The following is a description of a gene set: To identify tumor markers and differentiation markers for lung adenocarcinoma (AdC), we analysed expression profiles of genes against three cases of type II alveolar epithelial cells, bronchiolar epithelial cells, and bronchial epithelial cells, respectively, and 10 cases of AdC cells isolated by laser capture microdissection. Hierarchical clustering analysis indicated that AdC cells and noncancerous lung epithelial cells are significantly different in their expression profiles, and that different sets of differentiation markers are expressed among alveolar, bronchiolar and bronchial epithelial cells. Nine genes were identified as being highly expressed in AdC cells, but not expressed in noncancerous lung epithelial cells. Sixteen genes were identified as differentiation markers for lung epithelial cells. Real-time RT-PCR analysis of 45 lung AdC cases further revealed that expression of four tumor markers in AdC cells was significantly higher than that in noncancerous lung cells and that expression of ten differentiation markers was retained in a considerable fraction of lung AdC cases. Five tumor markers and seven differentiation markers were not expressed in peripheral blood cells. Similarities and differences in expression profiles between normal epithelial cells from different lung respiratory compartments and AdC cells demonstrated in this study will be informative for the molecular diagnosis of lung AdC. Differentiation markers for normal alveolar epithelium cells. Human Gene Set: NAKAMURA_ALVEOLAR_EPITHELIUM from publication Nakamura N, Kobayashi K, Nakamoto M, Kohno T, Sasaki H, Matsuno Y, Yokota J (PMID 16491115) species: Homo sapiens, and this is the list of marker genes: CLDN5, HIGD1B, RARRES2, RFTN1, CFD (complement factor D)